Given this list of marker genes AKT2, USP8 (NCBI Gene Id 9101), NRG2, RPS27A, AKT3, UBB, ERBB2, UBA52, ERBB3, UBC, AKT1, RNF41, NRG1, here is a description of the gene set: Human Gene Set: REACTOME_DOWNREGULATION_OF_ERBB2_ERBB3_SIGNALING Downregulation of ERBB2:ERBB3 signaling studied in species Homo sapiens